The following is a description of a gene set: part of: PTEN Regulation species: Homo sapiens Reactome Pathway: Regulation of PTEN localization When monoubiquitinated by E3 ubiquitin ligases XIAP and NEDD4, PTEN translocates from the cytosol to the nucleus. USP7 (HAUSP)-mediated deubiquitination of monoubiquitinated nuclear PTEN promotes relocalization of PTEN to the cytosol., and this is the list of marker genes: UBA52, PML (PML nuclear body scaffold), NEDD4, USP7, PTEN, UBC, XIAP, RPS27A, UBB